The following is a description of a gene set: part of: Signaling by Retinoic Acid This event has been computationally inferred from an event that has been demonstrated in another species.<p>The inference is based on the homology mapping from PANTHER. Briefly, reactions for which all involved PhysicalEntities (in input, output and catalyst) have a mapped orthologue/paralogue (for complexes at least 75% of components must have a mapping) are inferred to the other species. electronically inferred by orthology from the curated human pathway species: Mus musculus Reactome Pathway: RA biosynthesis pathway, and this is the list of marker genes: Akr1c18, Dhrs9, Dhrs4, Akr1c6, Akr1c20, Rdh10 (retinol dehydrogenase 10 (all-trans)), Cyp26b1 (NCBI Gene Id 232174), Aldh1a2, Sdr16c5, Adh4, Dhrs3, Rdh5, Cyp26a1, Crabp1, Akr1c14 (aldo-keto reductase family 1, member C14), Akr1c13, Aldh8a1, Akr1c21, Aldh1a3